Given this list of marker genes LTBP1, ADAMTSL5, ADAMTSL2, POLR2A, LTBP2, VWA1 (von Willebrand factor A domain containing 1), here is a description of the gene set: studied in species Homo sapiens Human Gene Set: GOMF_MICROFIBRIL_BINDING Binding to a microfibril, any small fibril occurring in biological material.